The following is a description of a gene set: studied in species Mus musculus Mouse Gene Set: GOBP_NEGATIVE_REGULATION_OF_DNA_TEMPLATED_TRANSCRIPTION_INITIATION Any process that stops, prevents, or reduces the frequency, rate or extent of DNA-templated transcription initiation., and this is the list of marker genes: Ctnnbip1, Myc, Hmgb1, Hey2, Morc1, Zfp451, Zfp473, Thra, Bmyc